The following is a description of a gene set: Mouse Gene Set: GOMF_JUN_KINASE_KINASE_ACTIVITY species: Mus musculus Catalysis of the phosphorylation of tyrosine and threonine residues in a c-Jun NH2-terminal kinase (JNK), a member of a subgroup of mitogen-activated protein kinases (MAPKs), which signal in response to cytokines and exposure to environmental stress. JUN kinase kinase (JNKK) is a dual-specificity protein kinase kinase and requires activation by a serine/threonine kinase JUN kinase kinase kinase., and this is the list of marker genes: Map2k6, Map2k5, Map2k1, Pbk, Map2k3, Map2k2, Map2k4, Map2k7